The following is a description of a gene set: studied in species Homo sapiens The injection of the pathogen-associated molecular pattern Polyinosinic-polycytidylic acid (poly(I:C)) leads to the activation of various immune cells, including dendritic cells (DCs) and Natural Killer (NK) cells. This activation is due to different innate cytokines produced early after injection, in particular IFN-I. The objective of the study was to compare the pattern of expression of IFN-I stimulated genes between DC and NK cells. The project focused on a specific subset of conventional DC, CD8a DC, which responsiveness to IFN-I determines the capacity to activate CD8 T cells by cross-presentation of exogenous antigens. To identify the responses to IFN-I selectively induced in CD8a+ DC, we compared their gene expression profile to that of NK cells, using gene chips, before and after poly(I:C) stimulation. Human Gene Set: GSE39556_CD8A_DC_VS_NK_CELL_MOUSE_3H_POST_POLYIC_INJ_UP Genes up-regulated after poly(IC) injection: CD8A dendritic cells versus NK cells. from publication Baranek T, Manh TP, Alexandre Y, Maqbool MA, Cabeza JZ, Tomasello E, Crozat K, Bessou G, Zucchini N, Robbins SH, Vivier E, Kalinke U, Ferrier P, Dalod M (PMID 23084923), and this is the list of marker genes: CTNNAL1, UBE2S, TROAP, BID, XRCC2, PAK4, HMMR, AP3B1, SLC7A1, KRT86, TUBG1, CDC20, EBP, ALDH7A1, CDC27, FOXM1, CKS2, KIF14, CEP131, PRKAR2B, HPRT1, KIF23, STK3, NEK2, EXO1, NUP155, APOBEC3B, CDC6, BARD1, CCNF, PKIA, ANP32E, PLK4, ATP1A3, C1orf216, CIT (citron rho-interacting serine/threonine kinase), NCAPD3, JCHAIN, CHEK2, CHEK1, POP7, DTYMK, HADH, CDK1 (NCBI Gene Id 983), HMGXB4, SMC4, NUDT1, KIF22, FANCG, BRCA1, FANCL, RNASEH2A, CDC45, GBA1, TRIP13, GPSM2, COQ2, CSE1L, PRPS2, NEMP1, GNAQ, DHFR, DDB2, RFC4, MTHFD1, BUB1B, BLM, MPHOSPH6, DBF4, FANCA, TUBB4B, SLC37A4 (solute carrier family 37 member 4), AKR1B1, ID2, TOM1L2, CLGN, CAMSAP1, PRPSAP1, HMGB3, RBBP8, CCNA2, DNA2, TTK, PAICS, ADCY3, SLBP, MTHFD2, NAB1, CENPA, SMC3, ARHGAP11A, TAF5, CCNB1, ZWINT, H4C13, TIMELESS, UMPS, TK1, TBC1D31, NUP205, POLE, CDKN2C, NCAPH, IFT25, CCNE2, PRIM2, HLTF (helicase like transcription factor), SKP2, LCP1, CEP43, TPX2, KNTC1, SLC30A3, GUCY1B1, COCH, TXN, CCNB2, LGALS3BP, CCNE1, PARP2, MACIR, DLG3, RRAGD, TRAT1, STIL, ACOT7, CDC25C, FHL1, POLE2, RRM2, H2AX, SERPINC1, SLC29A1, ARHGAP19, ACAT2, FANCI, LINC00342, NRGN, RPL39L, TMEM106C, TMPO, CHAF1A, REXO5, ERI2, H4C2, GMPS, PHGDH, SAPCD1, TCIRG1, MELK, DPYSL2, LIG1, PKMYT1, EFCAB11, GINS1, KIAA0586, ESPL1, VRK1 (VRK serine/threonine kinase 1), GALE, CTSW, AURKA, RRM1, CENPE, KPNA2, LAGE3, STAU2, TAF1B, IGFBP7, TOP2A, RFC3, TJP2, ICMT, CDC7, ZYX, CLIC4, CDKN3, GTSE1, POLA1, RAD51AP1, KIF2C, BUB1, CDK2 (cyclin dependent kinase 2), NDC80, PRIM1, KIF11, OIP5, CKS1B, SLC27A2, NET1, SPAG5, PIK3R3, RFC5, ABHD3 (abhydrolase domain containing 3, phospholipase), GGH, PFKM, HS2ST1, DLGAP5, KIF20B (NCBI Gene Id 9585), NEDD4